Given this list of marker genes JUN (NCBI Gene Id 3725), CDKN2D, CDC20, FECH, CSNK1G2, DDR2, MARCKSL1, MYC, GNB1 (NCBI Gene Id 87729), UBE2A, ITGA7, ARHGDIA (Rho GDP dissociation inhibitor alpha), APC, PAIP1, MYBL2, ELK1, GTF2B, HINT1, SYP, NFE2L1, F2R, HGF, TANK, PHB1, SPRY2, FGFR1, TSC2, CDC25A, CDH2, ERBB2, CCR1, CDK9, IL18, CCNT1, GNB2, CTNNB1, here is a description of the gene set: from publication Weigel AL, Handa JT, Hjelmeland LM (PMID 12419474) Oxidative stress plays a key role in aging diseases of the posterior pole of the eye such as age-related macular degeneration. The oxidative stress response of in vitro RPE cells has been studied for a small number of genes. However, a comprehensive transcriptional response has yet to be elucidated. The purpose of this study was to determine if the transcription of a common set of genes is altered by exposure of ARPE-19 cells to three major generators of oxidative stress, hydrogen peroxide (H2O2), 4-hydroxynonenal (HNE), and tert-butylhydroperoxide (tBH). As expected, a common response was observed that included genes differentially regulated by all three treatments. Of these, only one gene was upregulated, and only by one oxidant, while all other responses were downregulation. The majority of these genes fell into five functional categories: apoptosis, cell cycle regulation, cell-cell communication, signal transduction, and transcriptional regulation. Additionally, a large number of genes were differentially regulated by one oxidant only, including the majority of the conventional oxidative stress response genes present on the Clontech Human 1.2 microarray. This study raises questions regarding the generality of results that involve the use of a single oxidant and a single cell culture condition. species: Homo sapiens Oxidative stress genes down-regulated in ARPE-19 cells (retinal pigmented epithelium) in response to HNE and H2O2. Human Gene Set: WEIGEL_OXIDATIVE_STRESS_BY_HNE_AND_H2O2